The following is a description of a gene set: Genes containing one or more binding sites for (CDC73) in their promoter regions (TSS -1000,+100 bp) as identified by GTRD version 20.06 ChIP-seq harmonization. Human Gene Set: CDC73_TARGET_GENES from publication Yevshin I, Sharipov R, Kolmykov S, Kondrakhin Y, Kolpakov F (PMID 30445619) species: Homo sapiens, and this is the list of marker genes: PLEKHM3, ACTB, EHD2, C1orf56, AMD1, VPS39-DT (NCBI Gene Id 105370795), C7orf50, RUFY1-AS1, PIGV, SMARCC2, TIA1, TAP2, TMEM86B, RAD23A, SQLE, TMEM222, RASL11A, NFX1, ARHGEF17, PFDN4, CCDC144NL, IPO4, MAP7, LINC01719, ENSG00000232995, AGO2, RPS7, CTRL, MIRLET7I, LCP2, TRG-AS1, RBBP5, TIPARP, CICP14, TREM1, CIRBP, CFAP410, RPL27A, DPP9, PYGM, ARTN, TRGV7, LIMD2, HYKK, GNL3, NACA, TBX18, ARL5C, TOMM40, MIR4521, LINC02236, FMC1, DIAPH1, HES6, MIAT, RRAGC-DT, RPGR, MIR4530, STRN4, VTRNA1-1, RPL37, KLF7, PTPN6, KATNBL1, SACM1L, TSEN54, ESYT1, RBM4, SKIC2, MEF2C, DDX3X, REXO1, CUL9, HROB, SNHG8, CYBC1, H6PD, POLR2C, SLC14A2, HSPB1, FAM133B, HAGHL (hydroxyacylglutathione hydrolase like), USP11, TRIM65, CFAP206, CIRBP-AS1, BICDL3P, WDR6, ERICD, RPL31, IQANK1, WRAP53, BMI1, ATP8B2 (ATPase phospholipid transporting 8B2), TNFAIP8L1, DONSON, KDELR1, TPR, UTP25, LL22NC03-63E9.3, MAZ, NADK, RMRP, CRKL, ASB6, PLXDC1, DNASE1L2, AP5S1, TOMM20, SAMD10, SEC62, LINC02724, SBNO2, SRSF4, FANCC, SETD7, VAT1, LINC00237, KAT5, CORO6, MRPS26, FBXO34, NUP62, PTMA, ZNF34, ZFAS1, PPP1R27, ASB16, SNORD12C, ADAM17, FAM118B, AZU1, DVL2 (NCBI Gene Id 1856), NANOS1, ANKRD13D, RBIS (ribosomal biogenesis factor), SRCIN1, NCBP2, MEF2A, CDAN1, MIR153-1 (microRNA 153-1), RHOF, CCL27, SLC35E1, MIR4519, TRIM41, DUSP23, ADRM1, ABCA17P, ZNF839, SPOCD1, PRDM8, CREB3, EML3, RN7SL521P, USP15, ESAM-AS1, MUS81, LSM11, SLC3A2, NIBAN1, MIR762HG, U2AF2, LRRC24, ACTG1, BEND6, LINC02288, CPNE8, FBXO6, ZBTB37 (zinc finger and BTB domain containing 37), TEDC2, MROH6, CYB5D1, JPX, C11orf98, RNU6-9, ARHGAP45, TMBIM4, YBEY, MRPS15, MIR7845, MPPE1, MIR5708, CROCCP2, MYBPH, PTRH2, SNORA24, FUS, ADNP, ARL4A, AP2S1 (adaptor related protein complex 2 subunit sigma 1), NUF2, RHBDF2, SNORA57, PIN1-DT, CEACAM7, C15orf48, CASKIN2, FMC1-LUC7L2, EML6, MIRLET7IHG, PPP4R3A, LINC01569, TRGV4, EPC1-AS1, MIR616, PEX19, PITPNA-AS1 (PITPNA antisense RNA 1), MSTO1, E2F5-DT, KHDC4, MAFA, MCEE, IMPDH2, KNL1, MIPEPP3, BCKDK, ADAT1, PRPF6, SPNS1, SLC25A38, ALOXE3, KBTBD4, NDUFV1-DT, NICN1, EPN1, EBPL, ZNF843, TATDN3, MTF2, CENPBD2P, NEK8, FAM162A, MIF4GD, GAS5, FBXO34-AS1, ZEB2, CENPS, BAIAP3, WDR70, ATP5MC2 (NCBI Gene Id 517), ITGAL, CA13, PRR7, GNG13, ZNF213-AS1, METTL26, TLN1, MED16, DTWD1, CCDC30, ELK4, TOMM6, ARFRP1, ATXN2L, CYP2E1, MST1P2, GTF3C5, MIR1238, MZF1, TMEM170A, ECI1, EHMT1, DDX18, MIR1284, TAFA2, LIMD1-AS1, RECQL5, PALM, SEZ6, UBE2G2, PHF1, MAPK8IP3, RND2, CTPS1, LENG9 (leukocyte receptor cluster member 9), NOL7, ZNF767P, ESAM, DALRD3, DUS2, C2orf42, MLX, CGRRF1, TUBA1B-AS1, EPC1, INKA1, ACBD4, ILF2, MGAT4B, CKB, CSKMT, SIRPB1, TUBGCP6, PARP2, AP2M1, MIR4512, ING1, ZC3H10, ROM1, HEXIM1, TRGV6, HDAC2-AS2, MAN2A2, TTLL12, TIMM50, FAM43A, SLC35B2, ISYNA1, WEE2-AS1, VARS1, PIAS1, TIPARP-AS1, NDUFS7, ISCA2P1, ADAMTSL4 (NCBI Gene Id 80075), HSPA6 (heat shock protein family A (Hsp70) member 6, NCBI Gene Id 3310), TLE6, SCFD1, CCDC138, RHOC, CLPB, MAN2C1, ARK2N, B4GAT1-DT, NOP14-AS1, INPP4B, RPS15AP11, ACBD3, MAP1LC3B, CFAP53, FBXL5, GOLGA5, PITPNM1, REV1, ODAD4, POLM, IMPA1, MBNL1, VPS39, MARS1, PARP12, LINC00680, HAX1, PABPC1L, LINC02684, TRABD, SGK3, FOXO3, NKIRAS2, EPHB3, FBXO22, SNRPD1, SAMD4B, NCL, H4C1 (H4 clustered histone 1), COL1A1, H2BC18, ZNF782, TMEM179B, CNBD2, MYL12A, ATG4D, PRAME, RN7SKP249, GGCTP1, DDX11L5 (NCBI Gene Id 100287596), THTPA, NOC3L, CDK9, TLL2, MED4, NLRX1, IGLV1-51, CCDC144BP, NAE1, FAM227B, CHD9, DNAJC9-AS1, VIRMA-DT, EXOSC6, PAFAH2, BOLA1, REPS1, EPOR, FRS3, VLDLR-AS1, CEACAM21, POLR3E, ADISSP, ABCB10, HDAC10, RPSA, TP53, ZNHIT6, SMURF2P1, BNIP1, OSGEPL1, DDX11L10, CDK5RAP3, NEK6, LINC02960, H2AC6, RPL18, EXTL3, SUMF2, TMEM230, EPRS1, RBM17, MED23, NCOA7, CD55, NFE2L2, ING5, LIG4, VTA1, DECR2, PBRM1, GRN, TAF1C, EDC4, TRPC4AP, MIR6853, MEX3C, MBD6, POP5, TMEM14EP, LINC02558, SLC4A8-AS1, ACLY, PEA15, ENSG00000280424, SCARNA2, CYC1 (cytochrome c1), ABCA3, CALML4, TLE1, CDCA5, TSSC4, NDUFS3, COG2, ARID2, FOXJ3, MIR155HG, P4HB, LINC00853, PANK2, H4C8, SRP9, UQCC5, FIS1, PTBP2, EXOSC3, IER2, SNRPE, SKIL, ANKRD46, STXBP3, DMAP1, MCRIP2, TRIM3, PCID2, NXF1, MTFR1L, ENPP3, NCBP2AS2, KDM2A, CASTOR3P, MMP14, FHL1P1, LASP1, SNORD15B, TBL1X, SNAPC5, RNU7-140P, RAB32, FLT3LG, ZFPL1, B4GALT7, LSM2, PIN1, DQX1, SGF29, HSF1, HNRNPC, POLR3B, SELENOO, BAHCC1, TTC27, ATP2A1 (ATPase sarcoplasmic/endoplasmic reticulum Ca2+ transporting 1), EIF4G2, C5orf24, APTX, ENSG00000225032 (NCBI Gene Id 102723566), SNHG7, VIRMA, PPP6R1 (NCBI Gene Id 22870), RRAGC, ATF5, GPT, SNORA13, CUL4A, ODR4, MPHOSPH10, MIR4740, TBC1D4, DPP7 (dipeptidyl peptidase 7), PSMB3, ALG5, MAD1L1, GRWD1, TTYH1, GPS2, SNORA14B, CYRIB, SENP6, NCKIPSD, COL9A2, NDUFV1, TFEB, GPR79, FCHSD2, FASN, MIF4GD-DT, ZFHX2, RRP7BP, CENPS-CORT, KDM3B, PRKCG, PRRT2 (proline rich transmembrane protein 2), SSBP1 (single stranded DNA binding protein 1), TBX6, FBXO31, RBM23, BEGAIN, MYO15B, EMILIN2 (elastin microfibril interfacer 2), IQGAP2, DM1-AS, FDX2, CC2D2A, PPP4C, PABPN1, NUFIP2, ZNF516-AS1, CHAC2, INPP5K, LRRC41, LAMA5, SLC24A1 (solute carrier family 24 member 1), MCM3AP, CFAP418, ZFP69B, PNRC1, B4GAT1, GAPDH, HNRNPU, TSC2, PDE4A, B3GALNT2, GUSBP5, MRPL58, H2BC21, C19orf81, MFSD4A, MIX23, JADE1, TUSC2, ATP6V0E2, SCAMP3, PABPC1, INTS14, CD68 (CD68 molecule), TTLL3, CLK3, CDH24, SECISBP2, CHCT1, ITGA3, CSK, EPB41L4A-AS1, PLCD1, ACTN1, DHPS, MIR6728, DTWD2, ATN1, LTA4H, NDUFC1, TMEM106A, CRNDE, UQCR11, SMG7, LINC01623, MRPL13, DLEU1, CTSC, ZNF425, IER5, FRG1-DT, AHCTF1, MTBP, SNORA7A, EXOSC8, MYNN, CBL, VEZF1, UNC13D, ADGB, MYO1F, ZNFX1, ATP2A1-AS1, TADA2B, TUT1, SLC2A4RG, CYP4A22-AS1, ABHD13, ARHGEF16, DNAH7, ADD1, ZNF385A (NCBI Gene Id 25946), ZCCHC4, RPPH1, RGS5, ASB3, PRMT3, PLEKHG2, SLC4A8, FRG1CP, SLC16A3, SEC22B, TPM4 (NCBI Gene Id 7171), ENSG00000233030, MYADM-AS2, USHBP1, SNORD72, ZNF398, BCLAF1, TRGV1, RINT1, FRG1, ASCC2, DST, LINC01424, LINC01322, TCIRG1 (T cell immune regulator 1, ATPase H+ transporting V0 subunit a3), ABTB1, IL4I1, SNAPC3, SLC25A20, CERS2, RAD52, FXN, SATB2, SCAND1, LINC02695, RILP, MTERF1, EDEM1, NBEAL2, MTIF2